Given this list of marker genes COQ10A, ISG20, ASXL1, PATJ, MAPK13, RAB43, XPC, IFFO2, DDX56, ESYT1, KLHL22, SUPT20H, PRKCQ, HIVEP2, MDN1, CNST, DOCK9, CD27, ANKLE2, TNKS1BP1, ITPKB, ECHDC2, PACS1, CDR2, ITPR3, NIPAL3, LCK, KIAA0586, ABCC10, MAD1L1, ATP6V0E2, GPR55, LPCAT4, CHD3, BATF, UTP4, SPIN3, PHC1, REXO2, CBX7, TECPR1, HINT1, TTC9, HMOX2, ARID5B, DALRD3 (NCBI Gene Id 55152), TMEM63A, MRPL38, GPR183, TOX2, HSPB1, STAT5B, SSRP1, AMMECR1, IGSF9B, LNPEP, MAP3K14, HAPLN3, SGF29, FGD3, PBXIP1, TCF7, PLCG1, SIGIRR, CBR3, RNFT2, DIS3L2, ASH1L, LEPROTL1, EPHA4, CLPP, BCKDHB, MLLT3, FAM107B, SPOUT1, CD274, FBXW7 (F-box and WD repeat domain containing 7), DDX42, MAP4K2, OPTN, IL11RA, APBA3, MAST4, NSUN5P1, DGKA, MORC4, STING1, TP53I13, SLC25A23, ZNF335, RBFA, SEPTIN1, PIEZO1, CDRT4, LY9, EDEM1, RUNX1, ENSG00000284691, USP20, CD2, DEXI, EPB41, BAG3, PBX4, ANKH, GOLGA7B, DCP1A, LRRC8A, CD6, GATA3, ITGA3, ZNF575, TRIM62, TMEM116, DDX24, ABI2, RHBDD2, MAF, PHF3, PAG1, SLC9A3-OT1, PELP1, UBASH3A, CD84, PIK3IP1, ADSL, MAL, MARCHF9, ZNF862, TCF20, USP47, ABCC1, PHF1, PCNX2, HNRNPLL, PRDX2, LRIG1, RHOH, TMEM14A, EDC4, LINS1, OCIAD2, LRP8, ATXN7L1, ZFP90, SLAMF1, TENT4A (terminal nucleotidyltransferase 4A), TRBC1, RNF214, FBXL8, SERGEF, FAM117A, GLG1 (NCBI Gene Id 2734), HECA, KMT2A, DNAJC16, TLE5, THAP4, ESF1, SMYD2, EHD1, RASGRF2 (Ras protein specific guanine nucleotide releasing factor 2), NFRKB, DYRK2, NOP56, RFNG, S1PR2, IPO5, AGFG2, GALNT12, PHACTR2, IPCEF1, TNIK, RHOF, ARFIP2, ANKRD12, TBC1D4, ZNF251, C11orf68, MPRIP, PRMT7, MAP4K1, WWP1, TRIM16, LIME1, SUSD3, NOSIP, CACTIN, TJP3, VOPP1, ABHD14A, NCDN, FNBP1, TRIB2, ITK, CD5, NSMCE4A, WDR59, here is a description of the gene set: Human Gene Set: GSE11057_CD4_CENT_MEM_VS_PBMC_UP Microarray deconvolution is a technique for quantifying the relative abundance of constituent cells in a mixture based on that mixture's microarray signature and the signatures of the purified constituents. It has been applied to yeast and other systems but not to blood samples. Here we test the ability of this technique to determine the fractions of subsets of memory T cells in peripheral blood mononuclear cell (PBMC) samples. Genes up-regulated in comparison of central memory T cells versus peripheral blood mononuclear cells (PBMC). studied in species Homo sapiens from publication Abbas AR, Wolslegel K, Seshasayee D, Modrusan Z, Clark HF (PMID 19568420)